Given this list of marker genes CYP4A11, CYP4F2, CYP1B1, CYP1A2, CYP1A1, CYP2U1, CYP2C9, CYP2C8, CYP2C19, here is a description of the gene set: part of: Arachidonate metabolism Reactome Pathway: Synthesis of (16-20)-hydroxyeicosatetraenoic acids (HETE) Similar to the lipoxygenases, cytochrome P450 (CYP) enzymes catalyse the hydroxylation and epoxygenation of arachidonate. However, whereas lipoxygenases use an active non-heme iron to abstract hydrogen directly from arachidonate, CYPs contain a heme-iron active site that oxidizes its substrate by a different mechanism. They hydroxylate arachidonate between C-5 and C-15 to produce lipoxygenase-like hydroxyeicosatetraenoates (HETEs) and add a hydroxyl moiety to the sp3-hybridized omega-carbons to form a unique class of HETEs. The transfer of oxygen to the unstable arachidonate intermediate terminates the reaction by forming HETE or epoxy-eicosatrienoate (EETs), respectively. species: Homo sapiens